The following is a description of a gene set: studied in species Homo sapiens Human Gene Set: HP_LARGE_PLACENTA Large placenta Increased size of the placenta., and this is the list of marker genes: MEG3, LBR, SKIC3, LMNA, DLK1, ZMPSTE24, MKS1, RTL1